Given this list of marker genes Bmp2, Dgkq, Dkk3, Bmp5, Wnt4, Atp1a1, Nr3c1, Rest, H6pd, Nr5a2 (nuclear receptor subfamily 5, group A, member 2), here is a description of the gene set: species: Mus musculus Mouse Gene Set: GOBP_REGULATION_OF_GLUCOCORTICOID_BIOSYNTHETIC_PROCESS Any process that modulates the frequency, rate or extent of the chemical reactions and pathways resulting in the formation of glucocorticoids.